Given this list of marker genes RAB4A, UBE2G1, PTPRM, SLC25A1 (solute carrier family 25 member 1), AQP1 (NCBI Gene Id 358, aquaporin 1 (Colton blood group)), EGR4, TCN1, HPCAL1, SLC11A2, TM4SF4, POLR2C, HMGCR, CR2, PWP2, ANK1, ZNF212, DHCR24, SP140, SNTA1, GPKOW, PPARD, TNK1, BIK, COL18A1 (collagen type XVIII alpha 1 chain), ICA1, DOK1, CYLC2, TERT, P2RX4, EDC4, STAR, LTBP1, IL2RB, PLOD2, NDUFB7, MTF1, HTR3A, GPR176, PDE2A (NCBI Gene Id 5138), IL6R, TROAP, SERPINI1, HRC, IL15RA, ARPC1A (NCBI Gene Id 10552), CBR1, TRIP10, SLC28A1, TAX1BP3, RGS4, KLHDC3, SH3GL1, NKRF, IGF1R, EPB41, ARHGAP35, PCSK7, TRIO, COG2, PRKCH, CX3CL1 (C-X3-C motif chemokine ligand 1), CDH11, TCP10L3, RAB31, SNX1, DRD3, THBS4, KCNJ10, MYLK, PDAP1, PHLDA1, here is a description of the gene set: Genes in the cancer module 120. Human Gene Set: MODULE_120 species: Homo sapiens